Given this list of marker genes CHD2 (chromodomain helicase DNA binding protein 2), ALKBH2, GRINA, USP1, SLC11A2, SHLD2, WAS, ATF4, ANO1, TERB1, ACER2, TMTC3, TOP3B (NCBI Gene Id 8940), PSEN1, PEX2, UBE2NL, USP44, BCL2L12, ERCC1, MICA, MIR431, MALAT1, PRKD1, CLGN, ABCC9, REV3L, KIN, FAM168A, ENSG00000293600, MAP1LC3A, CDC7, SP100, TENT4A, SPATA22, NUDT16L1, CBX8, ACTL6B, XRCC5, CLSPN, SMARCA5, PPARD, ATG13 (NCBI Gene Id 9776), PIF1, SP7, ACD, ACAA2, RTN4R, FNIP1, INO80, SMARCD1, NCOA7, H2AX, RAD54L, CYP1B1, WNT2B, XRCC1, INO80D, MTREX, ERCC3, PARK7, SLC2A1, SESN1, IRAK1, MIR145, CALR3, PRKAG1, DDIT4, PARP4, KAT5 (NCBI Gene Id 10524), VASN, KDM1A, COPS5, ZNF365, HUWE1, PEX5, PPIF (peptidylprolyl isomerase F), ECPAS, ATP2A1, NUAK2, UBXN1, BRCA1, TNFRSF1A, FAF1, COMT (NCBI Gene Id 1312), TNF, PRKACG, RAD51C, RNF7, EIF4G1, KAT2B, TP53INP1, CHCHD6, MIR140, TRPV4, DNA2, LPCAT3, PAK3, IRF3, ZNF385A, HSPA8, FBH1, MAGEA2B (MAGE family member A2B), PARP1, HAS2, NCOA6, CD2AP, MIR200C, MIR103A1, MTOR, SMARCA4, RRAGA, WNT1, TMEM67, INPP5F, ASCC2, EGLN2, PLK1, IKBKE, SLC7A11 (NCBI Gene Id 23657), UBXN6, CREB3L1, DERL3, HTRA2, EPHA2, IKBKB, EGLN1, NUCKS1, FICD, EDEM3, LONP1, RIPK2, TMEM33, BTG2, VAV3, CXCL10, FIRRM, GSR, SIRT4, RET, USP43, BCL2A1, IMMP2L, RBM4, ZFYVE1, SUPT16H, PNPT1, MIR199A1, USP25, MSH5, CCM2, AQP3, MIF, RPA2, GAS6, GPR155, SMC5 (structural maintenance of chromosomes 5), ABRAXAS1, MAP1LC3C, UBE2U, CEBPE, PDK4, HLTF (helicase like transcription factor), NFAT5, POT1, CTH, HMGA1, AKR1B1, USP9X (ubiquitin specific peptidase 9 X-linked), SF3B3, DHX36, DNAJC7, BRD4, PARP10, CLCA1, PRKAG2, UACA, ANKLE1, MEAK7, PTEN, ATF2 (NCBI Gene Id 1386), MIR222 (NCBI Gene Id 407007), TRAF6, BDKRB2, RBL1, CRADD, SEMA4C, YBX3, CENPS, MIR10A, NSMCE2, EDN1, STOML2, AFF4, PRDX3, MAP3K13, CIB1, LARS1, WNT4, MC1R, TONSL, NRBP1, EGFR, ABL1, E2F7, UFM1, OS9, RUVBL2, TERB2, FADS2, APAF1, KLF4, CBS, UBXN10, POLN, ATRIP, MAN1B1, RAD51AP1, DCLRE1C, ETV5, ATXN7, TAOK2, DCUN1D5, SUMO1, RFC1, NPC1L1, YWHAE, PCNA, OXSR1, PRKCH, TOP2A, SLC1A1, FBXO6, FAM162A, TAF2, MCM2, DPF2, ERCC8 (NCBI Gene Id 2075), CLU, MSH2, SCARA5, RNF183, PACRG (parkin coregulated), MPV17, TEX12, KRAS, SP1, DHX9, ANKZF1, DDB1, GINS2, SRPX, CREB3L2, ENSG00000274276, FIGNL1, RBBP8, UPP1, CEBPA, POLI, CRYGD, MORC2, PRAP1, TGFB1, APBB1, CARD9, TNR, VHL, TTI1 (NCBI Gene Id 9675), BCL7B, TRIP12, EI24, AP5Z1, NFE2, NOTCH1, TELO2, PAK6, EMSY, SMC1A, IGFBP6 (insulin like growth factor binding protein 6), SLF2 (SMC5-SMC6 complex localization factor 2), FUT8, SMARCD3, KCNK2, RBM24 (RNA binding motif protein 24), ADCY8, NFATC2, IL26, RPS6KA1, ETAA1, KIAA0319, PTPRF, MORC3, HAPSTR1, ERLIN1 (ER lipid raft associated 1), PDCD10, OOEP, C1QBP, PPARGC1A, ENY2, FLCN, RMI2, USP33, PINK1, LIG4, YAP1, THY1, CCDC47, GINS4, RSL1D1, UBE2T, POLB, USP14, SLC39A5, SESN3, RNF175, SOD1, SAR1B, MSH4, TLK1, PIK3R2, EIF2AK3, TNRC6A, NIPBL, INSIG1 (insulin induced gene 1), FOXO1 (NCBI Gene Id 2308), ZNF277, USP45, TGFB2, SVIP, UBA6 (NCBI Gene Id 55236), RAD52, THBS4, WNT16, CLEC16A, RHBDD2, NIBAN1, UHRF1, SCARF1, ZMIZ1, DTX3L, ABL2, CERT1, STK38, CIDEA, THBS1, CLOCK, CCNK, ENDOV (NCBI Gene Id 284131), TMEM117, CHD1L, TP63, HRAS (HRas proto-oncogene, GTPase), INO80E, SPIDR, JAK2, UBE2D3, PRDX2, RRAGC, AJUBA, MAN1C1, MYOD1, MIR106B, ZNF432, SMARCA2, GPX8, BMPR1A, TDG, HMOX1, RFWD3, MIR221, CFL1 (NCBI Gene Id 1072), MIOS, GPR37L1, USP7, STAC, TPT1, MIR193A, DDR2, UBXN8, KDM2A, PRRX1, PIK3R1, FGFR2, USP13, MAPKAPK2, UFC1, BHLHA15, UBXN4, CDK1, IFI16, HSBP1, S100B, KLF2, TFDP3, C11orf54, JUN, RACK1, NSMCE3, SKP2, PPM1D, PAK5, PPP5C, PDGFD, DYRK2, IMPACT, FIS1, CANX, SPO11, RHNO1, SKIL, TERC, TRPV1, AIFM2, MIR448, SELENON, MCM6, HIPK2, DAG1, FABP1, ZNF580, GABARAPL2, CLN3, ATF6, AGAP3, ENO1, MYH13, PLA2R1, POLD3, KRT20, FOXA3 (forkhead box A3), PNPLA8, ASCC3, ALKBH3, AXIN2, PLK5, RRAGD, SH3GLB1, ELL3, MB, FBP1, RNFT2, ING3, TRIM39, NOD1, IL1A, CDKN1B, RNF138 (ring finger protein 138), ERMP1, DRD2, CDK3, TOPORS, GTF2H2C_2, CORO2B, RTN4RL1, ALOX5, CASP1, YPEL3, SLC12A6, SLC25A23, OMA1, RPA1, CFLAR, PAXX, SMUG1, SOX4, HSPA1B, NUDT2, FANCB, SLX1B, MEIOB, MPL, MAP3K7, PRR5L, AMBRA1, MARCKS, ACTL6A, MFSD2A (NCBI Gene Id 84879), SRD5A1, METTL3, RNF139, POLQ, TMED2, NDNF, MYO6 (myosin VI), TRPM2, RAD51B, AKTIP, BRAT1, VKORC1L1, TRIB3, CASP3, TAF7 (NCBI Gene Id 93080), DDIT3, SPINDOC, GFAP, BNIP3L, EME2, HSP90B1, RFC4, FNIP2, CSNK2A1, CBX1 (chromobox 1), PPP1R15B, NEK11, ARID1A, SAMHD1, FOS (Fos proto-oncogene, AP-1 transcription factor subunit), PIK3CA, IGF2BP1, PTN, PTGIS (prostaglandin I2 synthase), BATF2, KLHL15, LAMB2, SLC29A1, PRKCE, MAPKAP1, RTN4RL2, ZNF830, VPS72, VPS41, NFE2L1 (NFE2 like bZIP transcription factor 1), TMEM129, HSP90AB1, RAD50, BMAL1, INSIG2, FANCF, RPL26, GLRX2, RNF121, SPIRE2, POLDIP2, MOAP1, TRIM25, AIFM1, CHD4, BRF2, SPHK1, ELAPOR1, CEBPB, FAM111A, DDX11, DCLRE1B, COMMD1, EIF2B5, RAD21, GTF2H1, MAPK7, LIG3, RAD9A, TTI2, UCP1, PCK1, PPARA, WNK3, RNF167, OPA1, TAF4, ATR, SCAP (SREBF chaperone), ATP23, YY1, EDEM2, TAF12, YOD1, HSP90AB3P, BRIP1, SIRPA, CDKN2D, USP51, BABAM1, UBA7, ZCWPW1, CETN1, HM13, CDC5L, TNFRSF10B, HERC2, HMGB1, STK19, TADA2B, CEP63, CLCN2, ATG7, MIR107, PPP1CA, NRBP2, SEL1L, SMPD3, MAPK10, CHORDC1, UBAC2, GINS3, RFC2, EDEM1, FANCM, PMAIP1, SDE2, RBM11, ZBTB7A, USP47, PRKRA, MACROD2, CHAF1B, FOXN3, ALKBH8, CDK9, SUPT3H, ATP2A2, BCL2L1, SMC3, DAPK1, GPX5, SLC8A3, TRAF2, FOXRED2, CRY2, HTATSF1, QARS1, NDP, PCSK9, GATA6, SPRTN, MEIOC, RNF103, MLH1, NEFL, PTK2B, PXN, DNAJB14, SAXO1, CLPB, MORF4L2, RTEL1 (regulator of telomere elongation helicase 1), POLA1, MAGEA3, FOLR1, GDF15, GML, MBD4, CETN2, RBBP6, RPS6KA6, CCAR2, TBC1D7, PTTG1, AMFR, FANCL, ZFAND1, MTMR3, TEX15, MICU1, CAPN3, RPS6KA3, HP1BP3, USP22, HMGB2, SETX, SOCS5, PRKCD, RRM1, NUP62, UPF1, SEH1L, POLH, EPAS1, ERN1, DNAJC2, CFTR, UVRAG, TFEB, PAQR3, MAPK8IP2, CEP164, TAOK1, NPEPPS, MARCHF6 (NCBI Gene Id 10299), HUS1B, TIPRL, UBE2A, NSMCE4A, PCLAF, CDK7, AQP1, ZMAT3 (NCBI Gene Id 64393), MIRLET7B, PIK3CB, DYNLL1, RAD51, DYRK3, PMS2P5, PPP2CA, TRAP1, CCND1, BARD1, CITED2, VASH1, ARID2, SMARCE1, ENDOG, USP15, BGLAP, NHLRC1, BOK, DNAJB2, SELENOS, TFAP4, ATF6B, PMS2P1, ZRANB3, GTF2H4, LAMP2, UBR5, TRIP13 (NCBI Gene Id 9319), PCGF2, RWDD3, NCK2, CALR, RNF126, TICRR, FZR1, TOPBP1, SHLD1, TP53BP1 (tumor protein p53 binding protein 1), DDIAS, ISL1, ERCC2, KREMEN1, PHF10, RINT1, SETD1A, DHFRP1, SIRT3, MAN1A2, GAP43, FGF10, PAXIP1, COPS3, DPF1, MIR20B, SFPQ, EME1, MAP2K4, PEX12, PRDM9, GPR37, NQO1, ELP6, SDHD (succinate dehydrogenase complex subunit D), RTN4, SETD7, ZBTB7B, IFFO1, GNB1L, PAK1, STAU1, NINJ1, ING4, PDS5B, UVSSA, CTNNA1, BAK1, PRKN, CAB39, ESCO2, LRRC8D, RNF186, GPS2, SLC9A1, TM7SF3, NHEJ1, MPG, RAD18, PRDX5, BRME1, BRD7, DGCR8, NEK6, ZBTB1, HLA-G (NCBI Gene Id 3135), MLST8, ATG10, TANK, TAF5, MAP3K5, CRY1 (NCBI Gene Id 1407), BCL2L2, RNF169, WDR45B, SRXN1, TRIM32, MCM5, EIF2AK2, OTUB1, SGF29, OPTN, CGAS, NSMCE1, NSD2 (nuclear receptor binding SET domain protein 2), PLEKHA1, WDHD1, FOXP1, FIGNL2, PRDX1, HSPA1A, LYN (LYN proto-oncogene, Src family tyrosine kinase), SNCA, TBX3, ZSWIM7, PTK2, RUVBL1, MAP2K7, HIKESHI, MAPK12, IGBP1, UIMC1, SETMAR, PPARG, SZT2, YME1L1, ERP44, NBN, FBXO22, GTF2H2, CARTPT, SPI1, MDM2, BID, PIK3R4, OPRM1, RGMA, BATF, ZGRF1, HSP90AA2P, SLU7, HDAC3, MAPK14, MAP2K2, WDR45, HELB, CDIP1, ATXN3, RRM2B, ANKRD1 (NCBI Gene Id 27063), SMARCC1, MSTN, EYA1, RBBP5, MIR132, BECN2, P4HB, SRC, RAD21L1, STOX1, CEBPG, TRAIP, NCCRP1, PTTG1IP, WDR48, TPR, WFS1, CBL, MTSS1, MNAT1, NFE2L2, MIR21, RRP8, CASP2, NKX3-1, PDCD6, PGK1, EP300 (NCBI Gene Id 2033), ATP13A2, ITPR1, CASP4, LRRC8E, RNF152, TMEM259, DNAJA1, BNIP3, MIR210, PTPRS, GSTM1, PIK3C2B, DNAJC3, PENK, RCN3, CPEB4, ALOX15, NME3, NFE2L3, SIRT7, REC8, PAGE4, PHF1, CXCL12, MSH3, SYCP1, ROMO1, REXO4, PIN1, HILPDA, MRGBP, VCP, SWSAP1, JKAMP, MYB (MYB proto-oncogene, transcription factor), BRCC3, PHLDA3, AK4, FANCA, ST8SIA1 (ST8 alpha-N-acetyl-neuraminide alpha-2,8-sialyltransferase 1), TADA1, ACTR8, UBE4A, BAG3, PRKACA, BCL7A, MASTL, SMARCAL1, WDR4, TMCO1, RNASEH2A, XBP1, POLK, FOSL1, MIR22, DNAJA3, MANF, PDIA4 (protein disulfide isomerase family A member 4), ATF3, PARP8, FMN2 (formin 2), HDAC6, GEN1, TPM1, TRPC6, POGZ, ACTR2, ADAM17, EEF2K, HGF, FAS (Fas cell surface death receptor), USP3, TOP2B, BCL2, REST, DNAJB9, NACC2, SENP3, GFI1, SUV39H2, CBX5, EXO5, CDKN2A (cyclin dependent kinase inhibitor 2A), DYRK1A, SLC52A3, NUAK1, PYHIN1, RFC5, SUPT7L, TRIM13, TMEM161A, BAZ1B, HELQ, MAGEA2, PICK1, APC, PTPN2, SMC6, ERN2, ATG14, BCL7C, ACTR5 (actin related protein 5), BCLAF1, B2M, SETD2, DAXX, OXR1, PPP2R5C, FXYD2, PDIA2, EDNRA, DERL1, MACROH2A1, GTF2H3, UBR4, BFAR, SLC38A3, POLE2, GTSE1, SUV39H1, QRICH1, SLC25A24, CRIP1, PRPF19, DDX1, CREBZF, CHAF1A, SLC4A11, KMT5C, CBX3, MACROD1, OMG, AKT1, PMS2P6, ALDH3B1, APEX2, PARP3, TAF9, YJU2, MCMDC2, SFR1, FADS1, HDGFL2, SAMTOR, ABCB1, HIPK1, PRKCG, EEF1D, PRKACB, SERP1, MCTS1, GFRAL, IL18BP, SYVN1, TARDBP, CCNA2, AIM2 (absent in melanoma 2), INO80B, AVPR1A, GPX1, SGTA, RIOX1, BRSK1, FCGR2B, HSPA6, MYC, EFHD1, DNAJC18, BAD (NCBI Gene Id 572), G6PD, APLF, MUS81, NRBF2, MAPK8IP3, EIF2AK1, DMC1, SLC8A1, ERCC6, ATG5, PRIMPOL, ATXN3L, MEF2C, USP28, PSMC6, RNF34, URI1, MPND, SPDYA, XAB2, TOR1A, PLIN3, XRCC4, NGB, AQP5, TAF10 (TATA-box binding protein associated factor 10), OPRD1, NOS3, BRCA2, PRKDC, SESN2, TAF5L (TATA-box binding protein associated factor 5 like), INAVA, RPS3, PWWP3A, DNMT3A (NCBI Gene Id 1788), NFRKB, JAGN1, PYROXD1, PIAS1, CCDC13, HERPUD1, DDX5, ARMT1, CUL4A, CYBB, CD44, KMT5A, AEN, MAP2K5, UBQLN4, AKR1C3, CNTF, ZFP36L1, UBE2J2, MRNIP, PMS1, PPP4R3A, ALKBH7, MAP1LC3B, EIF2A, STX4, MDM4, PBRM1, TDP2 (NCBI Gene Id 51567), SREBF2, FBXO31, DNAJB12, GPX7, TET1, PDK2, RCSD1, TERF2, KIF22, OGG1 (NCBI Gene Id 93577), TMX1, RAD51D, PRKAA1, XRCC6, NOD2, CCS (NCBI Gene Id 9973), EXD2, RALB, RFC3, AGR2, IER5 (immediate early response 5), PPP2CB, SREBF1, IL6, TMUB1, MMS19, NEIL3, SCAMP5, SHLD3, SEC61B, MAP1LC3B2, ROCK2, GREM1, DPF3, DERL2, EZH2, MYBBP1A, RASGRF2, HMGA2, PAWR, EEF1E1, MIR126, GABARAPL1, POLG, CASP9, RIPOR1, PDS5A, TAF6, CAPN2, MCM7, STAT3, LRRC8C, GSTM3, CHEK1, MUC1, STK11, CPEB2, ID2, TLK2, AKT3, PEX14, FANCC, TMTC4, SEC16A, NEO1, ATRX, EID3, PRKAG3, SERPINB6, BATF3, EPC1, FXN, SNAI1, WDR76, HIF1A, PLK2, NUPR1, SMARCC2, PPP1R15A, TRIM28, TEX264, FMR1, ATP2A3, KRT13, WRAP53, MARCHF7 (membrane associated ring-CH-type finger 7), EGLN3, AP5S1, SIRT6, MAGEF1, FBLN5, RIPK1, ZBTB38, CSNK2A3, MAP2K1, HSF1, CSNK2A2, SUPT20H, USP10, PRKAA2, MTARC2, SFN, TNP1, NUDT1, KAT7, EPO, BCL3, PARPBP, UCHL5, KASH5, ARIH1, CXCL8, ADO, STC1, EEF2, PTGS2, ARL6IP5 (ADP ribosylation factor like GTPase 6 interacting protein 5), BMP7, UBE2N, SMARCAD1, UBXN2A (UBX domain protein 2A), FOXO3, GATA5, CINP, FLOT1, XRCC2, MAPK3, PDIA3, EXOSC10, RRAGB, CAT, ERLEC1, MCM3, GGN, FANCD2, SUMO4, MCRS1, PELI1, ZDHHC16, PLK3, STAU2 (NCBI Gene Id 27067), IKBKG, MAP1B, MGAT3, RECQL5 (NCBI Gene Id 9400, RecQ like helicase 5), NYNRIN, APTX, EIF2S1, PAK2, NOX1, SQSTM1, HIGD1A, GCN1, SLC39A4, WAC, UMOD, ZFYVE26, PIERCE1, STK24, TMBIM6, ULK3, PPP4R2, HMCES, TBX2, MTR, FBXO27, RNASEH2C, RBBP7, PARP2, CHCHD2, GIGYF2, BPGM, NFATC4, WDR59, KLF10, MRE11, RTCA, SPRED2, APP, RECQL, ELOF1, ASS1, MBTPS1, HSP90AB4P, RBBP4, ARHGEF2, ASTE1, REV1, MGARP, SOD2, SMG1, TCIM, SF3B5, ATMIN, PTPN1, MAJIN, NDUFS6, HERC5, ARG2, TMBIM4, MAP2K6, BBS1, ERCC4, GCH1, NDRG1, MMS22L, RPA3, FBXO17, PKD2, MIR214, SIN3A (SIN3 transcription regulator family member A), H2AC25, CD36, BBC3, GTF2H2C, INHBB, MBTD1, SHPRH, DNTT, TTF2, TMEM238L, PRKCI, UBE2V2, RHBDD1, AKT2, SLC2A4, FAAP20, GRM2, ATP1A1, TRIAP1, MSH6, SIRT2, NPRL2, SNW1, MCU, KDM6B, DDX3X, TMEM109, SERINC3, UBE4B, PMS2P3, NREP, BACH1, PARG (poly(ADP-ribose) glycohydrolase), CDK2, HUS1, ASF1A, MIR146A, SFRP2, MSL2, DMAP1, NTRK3, SLX4, GSTM2, TNC, RBM38, LCN2, FANCG, MAPK9, BCL2L10, SMCHD1, NUPR2, PARP16, SELENOK, ANG, PHF13, EPC2, MT3, MARCHF6-DT, YBX1 (Y-box binding protein 1), BLM, MEN1, FOXM1, RADX, AMBP, TRPV3, SAR1A, FANCI, TP73, DELE1, NRDE2, ZMYND8, USP19, AQP11, GTF2H5, C14orf39, ATP7A, YWHAZ, TWIST1 (twist family bHLH transcription factor 1), BCCIP, HDAC10, CD74, WRN, CDC45 (cell division cycle 45), ABCA7, FAAP100, BBS10, AUNIP, NTHL1, ACKR3 (NCBI Gene Id 57007), CTLA4, SMDT1 (NCBI Gene Id 91689), XPR1, UBE2G2, PPIA, UBQLN2, MLH3, LRRK2, ERCC6L, METTL1, PPP4C, FAAP24, EEPD1, NEIL1, MYLK, MCM4, MAPKAPK5, ZMPSTE24, RNFT1, PLIN2, UFL1, POLR2I, GNL1, SLC25A14, ARHGEF10L, KHDC3L, RPA4, TMUB2 (NCBI Gene Id 79089), APOA4, MCM8, BAX, SPRED1, PUM2, YEATS4, SEM1, MSRA, MIR543, FBXO2 (F-box protein 2), DEK, PDPK1, EHMT2, TAF9B, GABARAPL3, CAMKK2, JUNB, HNRNPA1, NEDD4, PLIN1, MMP2, SMARCB1, RNASEH2B, SCN7A, WDR24, HROB, BTK, TSPO, ATAD5 (ATPase family AAA domain containing 5), DSC2, CFAP410, UBQLN3, FLYWCH1, TAOK3, PJVK, FBXO4, EXO1, TSC2, PDK1, NPPA, MIR34A, PDGFRA, RWDD1, FBXO44, GABARAP, ERP29, MIR590, HMGN1, BECN1, XPA (NCBI Gene Id 7507), FOXO4, TMEM258, RIF1, CDKN1A, STT3B, BOD1L1, UNG, NF1, JUND, RNF168, ERP27, RAD23B, INHBA, KEAP1, NR4A2, FYN, ECT2, TFIP11, GRM3, CTBP1-DT, DHFR, NPAS4, TXNDC12, MET, XIAP, PALB2, PTPRK, SLC34A1, TNFRSF11A (TNF receptor superfamily member 11a), MIR96, EPHA4, WNK1, PPP4R3B, FGF1, GRB2, UBE2E2, TSC1, CYGB, DDB2, NBR1, TNFAIP3, KDM4D, STK33, CUL3, GCNA (NCBI Gene Id 93953), KAT6A, NME8, STXBP4, SSRP1, TRRAP, RASGRF1 (Ras protein specific guanine nucleotide releasing factor 1), UBQLN1, DDAH1, CDK5RAP3, SCIMP, NABP2, PAK4, OARD1, SFRP1, EYA3, MIR133A1, NAGLU, MCL1, KCND2, TREM2, MGME1, MAPT, ACTB, XPC, CAV1, MAPK13, GSK3B, MTA1, MTCH2, FBXO45, TAF6L, BAG6, TNKS1BP1, INTS3, UCN3, TIFAB, MGMT, MAF, UBA5, PEX10, FUS, SWI5 (NCBI Gene Id 375757), RIPK3, AIF1, FEM1B, FUT1, PEX13, AKIRIN2, NET1, POLM, ITFG2, WIPI1, RBX1, SHISA5, TTC23L, HSPD1, IER3 (NCBI Gene Id 91950), XRCC3, HRK, APOD, RPTOR, CUL4B, NEK4, SNAI2, DNAJC10, FAM8A1, RPS27L, PARP9, RNF113A, RAD17, ZNF668, ERO1A, POLD4, IL18RAP, SLF1, SLC38A2, ASH2L, LETM1, NFKBIA, CTC1, NCK1, ZKSCAN3, HSP90AA1, DGKZ, SIRT1, ADPRS, INTS7, MIR17, DUSP10, CSNK1E, PRELP, SLC30A9, NUDT15, CYREN, KPTN, VRK3, DNAJB6, CDC14B, PMS2, DAB2IP, PKN2, PRMT6, RAD9B, UBE2B, UBE2J1, NOL3, KAT2A, CRHBP, MAPK11, UFD1, RNF185, AGER, ASCC1, ADAM8, NPLOC4, BMPR2, MAP2K3 (NCBI Gene Id 92079), KLHDC10, NLRP3, CEBPD, PIK3C3, DCTPP1, MIR92A1, KCNK3 (NCBI Gene Id 3777), ATAD3A, TADA3, DTL, MAEL, LRIG2, PPP4R3C, EYA4, PYCARD, RAD54B, HYOU1, GLUL (NCBI Gene Id 2752), MCM10, HSBP1L1, PAGR1, CHRNA4, NR1H3, TERT, TREX1, HSF2BP, RORA, CASR (calcium sensing receptor), BRD8, GET4 (NCBI Gene Id 51608), TRIM21, MAP3K20, PYCR2, SLFN11, RPAP2, INIP, NEIL2, ULK1, POLL, MMP14 (matrix metallopeptidase 14), SUSD6, PTPN11, NEURL4, ASB11, NOP53, RAD1, KCNJ8, TIMELESS, XNDC1N, BABAM2, STX2, CASTOR1, LMNA, HDAC2, ABCC1, MCM9, DDRGK1, PML, APEX1 (apurinic/apyrimidinic endodeoxyribonuclease 1), TERF2IP, ABCD1, PIGBOS1, UBE2V1, SLX1A, DYRK1B, MIR217, SGK1, MATN2, HSPB8, ANGPT4, KIR2DL4, PYCR1, MAFB, MAD2L2, WRNIP1, MARF1, HERPUD2, KICS2, VRK1, CIP2A, SYF2, BRSK2, CPEB1, MAN1A1, TREX2, RNF5, CHAC1, BRAF, FER, ZC3H12A, MDC1, NPAS2, SOD3, MAG, LIG1, GCGR, GSTP1, INO80C, CERS2, ZBTB4, GBA1, RELB, SRF, PSMD14, CREBRF, HIF3A, TAF1, TNFRSF1B, MGST1 (NCBI Gene Id 4257), UBE2W, BCL2L11, NPM1 (NCBI Gene Id 4869, nucleophosmin 1), AUP1, PNKP, NABP1, TP53, MORF4L1, VAPB, TTC5, MBTPS2, ARNT (NCBI Gene Id 405), RCHY1, RHOB, TBC1D24, FANCE, DHRS2, ARID1B, TFPT, ABI3, STC2, CDKN2B, HSP90AB2P, ERCC6L2, PBK, YWHAG, ALB, CRYAB, RMI1, ERLIN2, WNK2, FEN1, ERRFI1, USP16, VCPIP1, GNAS, TOP3A, PDK3, SEL1L2 (SEL1L2 adaptor subunit of SYVN1 ubiquitin ligase), DOT1L, TDP1, HIC1, WNT9B, SMARCD2, RNF111, TIGAR, PSMD10, ING2, RELA, POLD2, ZBTB40, KMT5B, OSER1, OTUD4, MAPK8, GNGT1 (G protein subunit gamma transducin 1), MIR20A, AFG2B, TBL2, CCNB1, PPP1R10, ASNS, GRN, STK26, STUB1, TLR4, SCN2A, MAPK15, PRMT1, FH, CCDC117, PDIA6, PARP6, VRK2, RAD23A, HSPA5, DNAJC15, PDX1, SIPA1, MID1, AQP2, ABCB10, CREB3L3, SMYD2, ATXN7L3, STK39, MEAF6, MNDA, UBA1, ANKS4B, RNF8, TIPIN, FAN1, COMP, RGCC, SPRING1, NLK, WDR33, TMIGD1, CDCA5, EYA2, PPEF2, WIPI2, E2F1, MTARC1, TFEC, CIDEB, VPS13A, NONO, ECRG4, MIR135A1, MNT, GORASP2, SPP1, CREB3 (NCBI Gene Id 10488), RECQL4, FTO, RASSF1, ERCC5, MMP3, TXN, IRF7, MAPK1, CDK6, DCLRE1A, SERP2, STK25, VEGFA, MPO, GADD45A, DNAJB1, PSME4, FBXW7, DEPDC5, POLE3, ALKBH1, SLC7A5, JMY, THG1L, CDKN2AIP, MUTYH, CENPX, FAF2, GAS2L1, ZNHIT1, TRPA1, NR1H2, DONSON, EIF2AK4, UCP2, ATM, CREBBP, RNF145, PLEC, FBXO5, HPF1, SDF2L1 (NCBI Gene Id 23753), CHKA, NPRL3, CADPS2, HNRNPK, EP400, SCN11A (sodium voltage-gated channel alpha subunit 11), BCL6, POLD1, PIAS4, HINFP, SPIRE1, POLE, PIDD1, MSX1, CHEK2, BCAP31 (B cell receptor associated protein 31), here is a description of the gene set: Any process that results in a change in state or activity of a cell (in terms of movement, secretion, enzyme production, gene expression, etc.) as a result of a stimulus indicating the organism is under stress. The stress is usually, but not necessarily, exogenous (e.g. temperature, humidity, ionizing radiation). Human Gene Set: GOBP_CELLULAR_RESPONSE_TO_STRESS species: Homo sapiens